Given this list of marker genes ATAD2B, PARP11, METTL25B, NOX3, PSMA4, PGPEP1, PES1, RAD23A, NUP210, LUC7L, SEMA6A, MKRN2, BCL2, MRC2, NOC3L, CBX6, EXTL1, AOPEP, TSG101, CCNT2, SLC12A7, STIL, KDM2A, TUBB6, PLEC, KRT10, DPEP2, CRTC3, TBL1X, ERC2-IT1, TFE3 (NCBI Gene Id 8244), MED31, VPS4B, IPO5, CLMN, PTK7, NAA60, GMFG, MICAL1, PLCD1, BEX4, BCL3, LMNA, PRPF6, TBL1XR1, POLR1C, PTS, CLN3 (NCBI Gene Id 1201), TMEM11, ATP5MG, ADSL, HECA, KLF11, THOC6, BACH1, MAP1LC3B, NXT1, NDUFB4, NRDE2, GORASP1 (NCBI Gene Id 64689), MAST4, CLPX, RNASEH1, CCDC9, EIPR1, RPS20, FAM89B, WDR37, TMEM51, COL17A1, YES1, RBPJ, NLRP1, EIF4E2, TSC22D4, INPP5D, LGALSL, GAS8, SP3, CAST, UQCRQ, MOCOS, GUK1 (NCBI Gene Id 2987), SLC16A8, ATP11B, FUT4, DENND5A, FAU, NCAPH2, PPP5C, PSMG2, PRPF3, TRIM37, MFF, SULT1A2, DGUOK, TBXT, AFF4, KRT32, GYPC, MMP19, GNS, CCK, TNPO1, MYBBP1A, EP400, RAPGEF2, TERF1, CPZ (NCBI Gene Id 8532), LRRFIP1, CNP, ROGDI, ICE1 (interactor of little elongation complex ELL subunit 1), WDR45B, TRAF6, SERPINC1, TTLL1, ZBTB18, TMED1, PKD1P1, ERCC1, MATN2, UBAP1, CAPZA2, RHOG, ELAC2, CCDC51, PYCARD, PLA2G4C, SGSM2, BTBD7 (BTB domain containing 7), ARHGAP25, XKR8, ZMPSTE24, UPF1, SLC30A9, STX17, TMSB10, PSTPIP1, LGR5, IRF5, DAZAP1, MSX2, EMP3 (epithelial membrane protein 3 (MAM blood group)), RPLP0, CXCL1, CCZ1B, NOP2, GCKR, DEFA6, RBM4, H2AZ2, CFDP1, HTATIP2, TULP3, TTC21B, S100A5, EPM2AIP1, HOXC13, MAP3K13, CLDN17, SLC15A3, ECHS1 (NCBI Gene Id 1892), CCDC69, FKTN, RSL24D1, MOAP1, NSUN6, VCPIP1, MID1IP1, NEDD4, ARID5A, ZNF264, CYP21A2, CNOT4, UQCR11, MANF, GLB1, BRD3OS, ZFAND6 (zinc finger AN1-type containing 6), FHL3, USP3, LSM6, SMR3A, ADNP2, CPS1, DCTN6, RHOH, ARHGEF26, AIFM1, COPS3, BMERB1, ETHE1, SGPL1, EXOSC5, CCL24, RNF25, TRIM33 (tripartite motif containing 33), here is a description of the gene set: Human Gene Set: GSE29618_PRE_VS_DAY7_POST_LAIV_FLU_VACCINE_BCELL_UP Genes up-regulated in comparison of B cells from LAIV influenza vaccinee pre-vaccination versus those at day 7 post-vaccination. Systems vaccinology has emerged as an interdisciplinary field that combines systems wide measurements and network and predictive modeling applied to vaccinology. Here we used the systems vaccinology approach to study the molecular mechanisms underlying th species: Homo sapiens from publication Nakaya HI, Wrammert J, Lee EK, Racioppi L, Marie-Kunze S, Haining WN, Means AR, Kasturi SP, Khan N, Li GM, McCausland M, Kanchan V, Kokko KE, Li S, Elbein R, Mehta AK, Aderem A, Subbarao K, Ahmed R, Pulendran B (PMID 21743478)